The following is a description of a gene set: Human Gene Set: CAO_BLOOD_FLUMIST_AGE_05_14YO_30DY_DN from publication Cao RG, Suarez NM, Obermoser G, Lopez SM, Flano E, Mertz SE, Albrecht RA, García-Sastre A, Mejias A, Xu H, Qin H, Blankenship D, Palucka K, Pascual V, Ramilo O (PMID 24495909) BACKGROUND: Live attenuated influenza vaccine (LAIV) and trivalent inactivated influenza vaccine (TIV) are effective for prevention of influenza virus infection in children, but the mechanisms associated with protection are not well defined. METHODS: We analyzed the differences in B-cell responses and transcriptional profiles in children aged 6 months to 14 years immunized with these 2 vaccines. RESULTS: LAIV elicited a significant increase in naive, memory, and transitional B cells on day 30 after vaccination, whereas TIV elicited an increased number of plasmablasts on day 7. Antibody titers against the 3 vaccine strains (H1N1, H3N2, and B) were significantly higher in the TIV group and correlated with number of antibody-secreting cells. Both vaccines induced overexpression of interferon (IFN)-signaling genes but with different kinetics. TIV induced expression of IFN genes on day 1 after vaccination in all age groups, and LAIV induced expression of IFN genes on day 7 after vaccination but only in children < 5 years old. IFN-related genes overexpressed in both vaccinated groups correlated with H3N2 antibody titers. CONCLUSIONS: These results suggest that LAIV and TIV induced significantly different B-cell responses in vaccinated children. Early induction of IFN appears to be important for development of antibody responses. Genes down-regulated in blood 30d vs 0d in children (0.5-14y) after exposure to FluMist, time point 30D. Comment: ~80% of cohort were white, ~50/50 Female:male species: Homo sapiens, and this is the list of marker genes: XCR1, CBR1, HEMGN, SERPINA1, MGAM2, VPS41, LSMEM1, WASHC2A